Given this list of marker genes CD28, ECM1, DDB2, SASH3, IKBKG, CXCR4, ERCC4, DCLRE1C, IGLL1, KLLN, SDHC, TPP2, ERCC3, IVNS1ABP, STK4, MSH3, PIK3CA, ERCC5, CD79A, POLD1, CARMIL2 (capping protein regulator and myosin 1 linker 2), ICOSLG, XPA, PIK3R1 (phosphoinositide-3-kinase regulatory subunit 1), SDHD, RNF31, IL7, SDHB, IGHM, FCN3, CIB1, CD79B, SPI1, TMC6, SLC39A7, AKT1, TCF3, DOCK8, XPC, HRAS, BLNK, USF3, ATP2A2, PTEN, ERCC2, LRRC8A (NCBI Gene Id 56262), PDCD1, FLT4, CD4, TP53, TMC8, PORCN, GATA2 (GATA binding protein 2), RHOH, NRAS, SEC23B, SEC61A1, here is a description of the gene set: species: Homo sapiens A tumor of the skin or mucous membrane with finger-like projections. Human Gene Set: HP_PAPILLOMA Papilloma